The following is a description of a gene set: A multimeric protein complex that can methylate lysine-27 and lysine-9 residues of histone H3. In Drosophila the core subunits of the complex include ESC, E(Z), CAF1 (NURF-55) and SU(Z)12. In mammals the core subunits of the complex include EED, EZH2, SUZ12 and RBBP4. Mouse Gene Set: GOCC_ESC_E_Z_COMPLEX species: Mus musculus, and this is the list of marker genes: Suz12, Dnmt3l, Rbbp4, Phf1, Phf19, Rbbp7, Aebp2, Eed, Trim37, Ezh2, Epop, Sirt1, 9630013A20Rik, Mtf2, Chaer1, Hdac2, Jarid2, Ezh1